Given this list of marker genes FZR1, UFSP2, TBC1D24, GRIN2A, KCNH5, SLC25A22, ST3GAL3, SLC12A5, LGI1, FRRS1L, PACS2, KCNQ2, WWOX, KANSL1, GNB1, SCN8A, PCDH12, SMARCAL1, KCNQ3, SRPX2, ADAM22, DMXL2, PIGA, PLCB1, RELN, SCN1B, CUX2, COQ4, GLUL, GABRG2, SCN1A, GABBR2, PRRT2, MICAL1, GABRA1 (gamma-aminobutyric acid type A receptor subunit alpha1), KCNK4, GLYCTK, SCN2A, KCNT1, PCDH19, PEX3, SCN9A, ATP1A3, CACNA2D1, here is a description of the gene set: A focal clonic seizure is a type of focal motor seizure characterized by sustained rhythmic jerking, that is regularly repetitive. studied in species Homo sapiens Focal clonic seizure Human Gene Set: HP_FOCAL_CLONIC_SEIZURE